The following is a description of a gene set: Human Gene Set: ENK_UV_RESPONSE_EPIDERMIS_UP studied in species Homo sapiens Genes up-regulated in epidermis after to UVB irradiation. In order to obtain a comprehensive picture of the molecular events regulating cutaneous photodamage of intact human epidermis, suction blister roofs obtained after a single dose of in vivo ultraviolet (UV)B exposure were used for microarray profiling. We found a changed expression of genes. Half of the UVB-regulated genes had returned to pre-exposure baseline levels at 72 h, underscoring the transient character of the molecular cutaneous UVB response. Of special interest was our finding that several of the central p53 target genes remained unaffected following UVB exposure in spite of p53 protein accumulation. We next compared the in vivo expression profiles of epidermal sheets to that of cultured human epidermal keratinocytes exposed to UVB in vitro. We found genes that differed in their expression profiles between the two groups. The expression profile in intact epidemis was geared mainly towards DNA repair, whereas cultured keratinocytes responded predominantly by activating genes associated with cell-cycle arrest and apoptosis. These differences in expression profiles might reflect differences between mature differentiating keratinocytes in the suprabasal epidermal layers versus exponentially proliferating keratinocytes in cell culture. Our findings show that extreme care should be taken when extrapolating from findings based on keratinocyte cultures to changes in intact epidermis. from publication Enk CD, Jacob-Hirsch J, Gal H, Verbovetski I, Amariglio N, Mevorach D, Ingber A, Givol D, Rechavi G, Hochberg M (PMID 16434974), and this is the list of marker genes: S100A8, PITPNC1, PLSCR1, PPIB, FUT2 (NCBI Gene Id 93237), NISCH, CARHSP1, ATIC, CMAHP, DEFB4A, ENTREP3, KRT16, EIF4EBP1, TNFRSF25, ACTN1, GCLM, ADAP2, NAGPA, PSMA5 (proteasome 20S subunit alpha 5), PRMT5, DLX5, CCT7, TMEM165, AKR1B10, ENTPD3, HTR3A, ME1, NUPR1, DDB2, THBS2, DHRS9, NHLH2, CTSB, CCNG2, LIPG, SLC1A5, HOMER3, CBX4, DCAF8, POLE, ITGB4, OSMR, HCP5, APEH, TUBG1, ELAC2, PKP2, SNX7, RCC1, EBNA1BP2, IL24, IDH3A, DSG2, PRDX3, FDXR, STK25, S100P, TUBGCP2, TMSB10, DRG2, H4C12 (NCBI Gene Id 8362), ME2, NME3, SLC5A6, HEXIM1, STAMBP, GYS1, H2BC5, MYLK, GALE, PROCR, ANP32A, HK2, EIF2B2, MRPS31, PSME3, NFX1, USP20, PGAM1, NME6 (NCBI Gene Id 10201), ALDH1A3, AIFM1, AIMP2, TPD52L2, BCL11A, CEACAM3, TP53I3, F12, KRT6A (NCBI Gene Id 93086), RHCG, HP1BP3, WARS1, FLNA, RALB, CD47, LPXN, PIDD1, NET1, MTMR11, CACNB3, PTBP3, DPAGT1, PRSS22, ANAPC2, BTN2A2, PFKP, SFRP1, MANF, SCO2, MAP3K20, DPP3, PDHB, MMP3 (NCBI Gene Id 4314), RWDD2B, CHKB, SLC16A1, SNRPA1, CSTB, LSR, FAXDC2 (fatty acid hydroxylase domain containing 2), PALS1, PRSS2, SLC25A15, STK39, ESPL1, COPS7B, GRK6, RAB31, PYGL, RUVBL1, MMS19, CTSL, TBP, BCL2L1, CMAS, STX6 (syntaxin 6), M6PR (NCBI Gene Id 4074), SERPINB3, SULT1A2, TRIOBP, VRK2, FTH1, MYLIP, HILPDA, METTL3, HDAC1, BTN3A3, SH3BP2, SRM, ACTL6A, STAT3, PSMB2, ELF3, CHST2, GALNT6, TEAD4, TOLLIP, BMAL2, PDSS1, HGS, TYMS, TIGAR, CDH3, CSTF2, PIN4, XPC, XRCC1, KPNA6, MAP4K4, FXYD5, FUT3, ADSL, S100A7, DSC2, SHMT2, TGM1, NRG1 (neuregulin 1), MDFI, SQOR, PAFAH1B3 (NCBI Gene Id 5050), IFITM3, RBM5, PLCD1, MKKS, ETS1, PLXNB1, BCL3, MX1, ANXA3, MPHOSPH6, SLC2A1, PUDP, PGF, ULBP2, AR, SLC35B1, DNASE1L3, PRKAG1, IL6ST, SPRR2A, EHMT2, HPSE, PHLDA3, TNKS, AVPR1B, GSTO1, NELFE, PSMD3, CDC20, VLDLR, TREX1, KRT17, DAPK1, SFXN3, ACP6, COPZ2, CA2, FSCN1, SLC25A13, CSF1, JMJD7-PLA2G4B, NPIPB3, POU3F1, CAPN2, SP110, PPIH, SPG7, STRN (striatin), ENDOU, RGS20, CPNE1, OASL, ZNF212, TMPRSS4, CES2 (NCBI Gene Id 8824), SERPINA1, TNC, XPOT, UPP1, PREB, CSE1L, SURF2, ANGPTL4, G0S2, PRIM1 (DNA primase subunit 1), RRAS2, NUDT4, ZNRD2, TJP2, PDLIM7 (PDZ and LIM domain 7), HMGB1 (NCBI Gene Id 3146), KLF7, BNIP3, ST6GALNAC2, PPARD, NMT1, RAP1GAP, ADAM8, ARHGDIB, IP6K1, KXD1, HYOU1, ZYX, CD24P2 (NCBI Gene Id 936), SMS, DKK3, PSIP1, SEPTIN9, PIM2, TNFRSF10B, CD36, PLA2G3 (NCBI Gene Id 50487), SERPINB1, CERS2, CYB5R2, ITGAE, PRICKLE3, POLR3G, DNAJC7, RUVBL2, IRF7 (interferon regulatory factor 7), IL4R, AMPD3, HTT, CXCR2, CYP27B1, SORL1, EHF, PHB1, FKBPL, SRSF7, POLR2G, POLD1, MRPS7, PRKAB1, TGFA